The following is a description of a gene set: from publication Amit I, Garber M, Chevrier N, Leite AP, Donner Y, Eisenhaure T, Guttman M, Grenier JK, Li W, Zuk O, Schubert LA, Birditt B, Shay T, Goren A, Zhang X, Smith Z, Deering R, McDonald RC, Cabili M, Bernstein BE, Rinn JL, Meissner A, Root DE, Hacohen N, Regev A (PMID 19729616) Human Gene Set: GSE17721_PAM3CSK4_VS_CPG_16H_BMDC_DN mouse primary BMDCs were stimulated with tlr ligands and gene expression changes were profiled on Affymetrix arrays Genes down-regulated in comparison of dendritic cells (DC) stimulated with Pam3Csk4 (TLR1/2 agonist) at 16 h versus DC cells stimulated with CpG DNA (TLR9 agonist) at 16 h. studied in species Homo sapiens, and this is the list of marker genes: MX2, IGF2BP2, HLA-B, MORF4L1, SELENOM, IL10RB, ZNF524, TXNIP, PLVAP, PPP1R14D, MS4A3, POR, EPSTI1, STC1, SH2D3C, RHCG, CPLX1, ATP13A2, NUF2, NPRL3, RAB29, GARS1, MS4A6A, SH2B3, RHOC (NCBI Gene Id 389), GRINA, BRINP1, FIZ1, RPL7L1, ERGIC2, CCNL2, PLAAT3, PLEKHA2, GAPDHS, EXOSC10, CAPZA2, TAT, DTNBP1, RBM4 (NCBI Gene Id 5936), SH2D1A, SLC29A3, PLPPR4, MOB2, EPS8, TFAP2A, SNTG2, SLC1A3, DPEP1, PPP4R3A, LMNA, FSCN1, TRAPPC13, PLRG1, AGR2, SLC6A8, STX8, IQGAP3, SLFN12, F7, SERTAD1, RBM6, COPS4, IL7R, MARCHF5, VSTM2A, AXL, RSAD2 (radical S-adenosyl methionine domain containing 2, NCBI Gene Id 91543), TC2N, RGL3, LMO1, VPS39, JMY, NUDCD3, AGRN, ZDHHC5, SLC28A2, ADCYAP1R1, AUTS2, P2RX4, DENND4B, C5, TUBB2B, RAB9A, ECHS1, SWAP70, MRPL36, ZSCAN22, JUN, IL18BP, CCL13, RTCA, CCDC6, CSK, C1QA, ALKBH4, TULP3, CTSV, REL, LETMD1, THEMIS2, GRK1, NT5M, TYK2, SNRPC, TBC1D15, HOXC4, CHMP4B, PXN, ZNFX1, CCDC80, CCM2, NFATC1, HEY1, CFAP298 (cilia and flagella associated protein 298), FAM20C, CFL2, SLC25A22, CCNB1IP1, CHST4, HACD4, PSMB9, PES1 (NCBI Gene Id 23481), AP2M1, TGFB1I1, SLC13A3, VMP1, PSMB10, ABHD2, ATP5F1A, TRIM34, SDHA, PDLIM4, GBP6, CA13, CLIP1, EIF2S2, PGAM5, MIGA2, TP73, G6PD, B3GNT4, IL10, PTF1A, CRYZ, CD93, TMEM219, SERP1, APOBEC1, MET, SARS1, STAT4, CD200, CELA3B, DCLRE1A, SRD5A3, LPIN2, APOBEC3B, ANXA4, NKAIN4, PTTG1IP, PIAS4, SAMD10, AIMP2, CYSLTR2, TNFRSF10A, KANSL1L, SYNGR2, ANAPC16, ZNF397, ANKRD24, TRAFD1, OPRK1, GBP4, AR, GHRHR, UBE2L6, CARS1, MPP1, CAVIN3, KRT17, GIT1, IGBP1, RCC1, INPPL1, ALDH1B1, GMPPB, IL12B, RNASE4, SOX11, SF3A2, RASA3, PENK, APTX, SHISA5, C8A, B3GNT5, MED17, FABP4, ALCAM